The following is a description of a gene set: Human Gene Set: REACTOME_POLB_DEPENDENT_LONG_PATCH_BASE_EXCISION_REPAIR species: Homo sapiens POLB-Dependent Long Patch Base Excision Repair, and this is the list of marker genes: APEX1, LIG1, FEN1, ADPRS, PARP2, PARP1, PARG, POLB